Given this list of marker genes CSN2, CST8, SPOCK1, CSTL1, KNG1, FETUB, SNCA, BIRC6, CST3, SERPINB13, XIAP, BIRC5, CAST, CST9, CARD18, CST7, CSTA, CST5, SERPINB3, HRG, PTTG1, CST4, CST11 (cystatin 11, NCBI Gene Id 164378), CARD17P, CSTB, LCN1, NAIP, CST9L, CST2, BIRC7, WFDC2, CST1, LTF, CARD16, CST6, AHSG, CST9LP1, here is a description of the gene set: Human Gene Set: GOMF_CYSTEINE_TYPE_ENDOPEPTIDASE_INHIBITOR_ACTIVITY Binds to and stops, prevents or reduces the activity of a cysteine-type endopeptidase. species: Homo sapiens